Given this list of marker genes CCDC40, MSH4, CFAP74, DNAH11, PRLR, BTG4, TTC12, NME8, DNAAF1, DRC1, DNAH9, RSPH9, ODAD1, ASTL, KPNA7, DNAJB13, PANX1, ODAD3, MEIOB, RSPH4A, DNAI1, DNAAF4, RSPH3, ODAD2, CFAP300, WEE2, SYCP2L, NLRP2, NLRP5, REC114, DNAAF5, SPEF2, RSPH1, TRIP13, SPATA22, PSMC3IP (NCBI Gene Id 51769), FOXJ1, NME5, FOXL2, DNAAF3, ODAD4, CYP19A1, MOS, KASH5, GAS2L2, CFAP221 (NCBI Gene Id 200373), PGR, MSH5, OFD1, DNAH1, NEK10, TOP6BL, ZMYND10, DNAAF6, HSF2BP, STK36, ZFP36L2, HYDIN, ZP2, LRRC56, TLE6, FBXO43, GGPS1 (geranylgeranyl diphosphate synthase 1), TUBB8, CFAP298, POF1B, DNAH5, RPGR, DNAAF11, CHEK1 (NCBI Gene Id 1111), CCNO, CDC20 (NCBI Gene Id 991), DNAL1, MEI1, ZP3, DNAI2 (NCBI Gene Id 64446), SPAG1, CCDC39, ZP1, MCIDAS, FIGLA, PATL2 (PAT1 homolog 2), DNAAF2, here is a description of the gene set: Human Gene Set: HP_FEMALE_INFERTILITY Female infertility studied in species Homo sapiens